The following is a description of a gene set: Catalysis of the reversible conversion of pyruvate or oxaloacetate to malate. Mouse Gene Set: GOMF_MALATE_DEHYDROGENASE_ACTIVITY species: Mus musculus, and this is the list of marker genes: Mdh2, Me1, Me3, Mdh1 (NCBI Gene Id 83566), Mdh1b, Lipf, Me2